Given this list of marker genes Atp11a, Ms4a6d, Rab8b, Aebp2, Ddit4, Car13 (NCBI Gene Id 71934), Srp9, Tarm1, Kmo, Actn1, Nup88, Malt1, AA467197, Ffar2, Lilrb4b, Fcgrt (NCBI Gene Id 14132), Fosl2, Cd209e, Vdr, Gpr132, Fkbp1a, Zfand3, Tle3, St8sia4, Plekhg2 (pleckstrin homology domain containing, family G (with RhoGef domain) member 2), Map3k14, Bzw2, Zfp593, Id2, Acvr2a, Stk39, Rgs1, Syncrip, Clec4n, Ccdc102a, Pfkp, Apobec3, St6gal1, Apod, Serpina3g, Spred1, Rab14, Cd40, Tnfrsf11a, Prnp, Il1rn, Pcgf5, Mt1, Dynlrb1, Hbegf, Rtn4, Riok3, Ccnd2, Cd164, Hax1, Myh9, Samsn1, Cyp7b1, Cfl1, Klf9, Batf3, Cdk6 (NCBI Gene Id 330039), Ass1, Edem1, Vasp, Idi1, Arfgap3, Foxn3, Pogk, Arpc2, Map1lc3b, Litaf, Scn3a, Il4i1, Plet1, Arl8b, Ptger4, Slc30a4, Ngfr, Vcp, Rbx1, Eif5a, Dad1, Relb, Adam23, Zfp106, Marcks, Gpat4, Vmp1, Casp8, Rab7, Ikzf4, Pdcd1lg2, Eif3c, Hsbp1, Il1b, Wnk1, Swap70 (SWA-70 protein), Nipal1, Med15, Plekha1, Socs2, Stxbp6, Snd1, Abracl, Fdx1, Stat3, Cyria, Cyth1, Trpv2, Ddx6, Ms4a4c, Mrc1, Kdm6b, Rpain, Wfdc17, Atp1a1, Ext1, Csrp1, Hnrnpa3, Orai1, Eif2s1, Nckap1l, Itgb1, Btg1, Rabgap1l, Ubxn2a, Ncl, Tmed5, Necap2, Noct, Psme2, Gpr171, Ywhaq, Ly6a, Mrpl20, Pim1, Sec11a, Ccl12, Cox17, Cd300lf, Galnt7, Mbd2, St7, Tnip2, Col27a1, Abtb2, Psma6, Jtb, Casp6, Arhgap31, Arl5a, Ier3, Sf3b6, Eif6, Fh1, Rnf7, Socs3, Nfkb1, Tspan13, Aamp, Cish, Eif1ax, Zfp36l1, Sh3bgrl, Bcl3, Cd86, Xxylt1, Fndc10 (NCBI Gene Id 230991), Nfkbia, Nr4a3, Cd274, Uqcrfs1, Tmem123, Bzw1, Itm2c, Mob3a, Jaml, Ramp3, Gadd45b, Chd7, Sinhcaf, Slc7a11, Pde1b, Ehd1, Psmb7, Nfkb2, Gnai3, Etv3, Tubb6, Ly75, Cct3, Sh3pxd2b, Ptpn2, Lgmn, Clic4, Manf, Cflar, Runx3, Cdkn1a, Hs3st3b1, Pdlim5, Tfec, Cxcl16, Tagln2, Mllt6, Gmppb, Irf5, Socs1, Tpm3, Lrrk1, Cyrib, Uck2, Slc7a5, Ak2, Stat4, Slc33a1, Rcl1, Dusp2, Erh, Cfp, Kdm5c, Stat5a, Ahcyl2 (NCBI Gene Id 74340), Ube2i, Bcl2a1d, Gfra2, Pacsin2, Wtap, Dusp5, P2ry10, Ccr1 (C-C motif chemokine receptor 1), Ifitm2, Diaph1, Csrnp1, Crem, Id1, Sphk1, Ctsz, Ggta1, Cdk2ap2, Lrrc59, Zfc3h1, Syngr2, Prdm1, Mon1b, Il4ra, Csf2rb, Birc3, Mfhas1, Emd, Myo1g, Pik3r1, Adam8, Snap23, Ccl17, Mthfs, Arhgap30, Anxa2, Eif4a1, Fyn, Sdhaf1, Fkbp5, Ube2f, Gcnt2, Arap2, Rabep1, Plscr1, Rap2a, Fchsd2, Pnp (NCBI Gene Id 18950), Fabp5, Hif1a, Scimp, Slfn2, Nudt17, Mif4gd, Tpm4, Gpr183, Myl6, Srf, Mkrn1, Bcl2a1b, Actg1, Plk2, Zdhhc6, Dok2, Rras2 (related RAS viral (r-ras) oncogene 2), Rexo2, Pmvk, Nectin2, Nras, Ost4, Cd63, Nuak2, Lmnb1, Ube2j2, Tmbim1, Adprh, Ifitm1, S100a6, Basp1, Oasl2, Myl12a, Eloc, Timd4, Eif1, Hsd11b2, Mdh2, Hnrnpll, Lrrc8c, Nfil3, Trip12, Pfn1, Ppa1, Zfp296, Lilrb4a, Ube2m, Psmd11, Fem1c, Mir155hg, Picalm, Ccr7, BC031181, Calr, Rab21, H2-Eb2, Pkib, Gsr, Fabp4, Flot1, Ptpn4, Mt2, Rspry1, Sar1a, Map4k4 (mitogen-activated protein kinase kinase kinase kinase 4), Ankrd33b, Srsf2, Dab2, Tmem131l (NCBI Gene Id 229473), Fth1, Arfgap2, Bach1, Marcksl1, Cytip, Rel, Pgk1, Rbm3, Prkcd, Txndc17, Ciao2b, Rai14, Sdc4, Fscn1, Htr7, Arpc5, Frmd4b, Ccl22, Dnajb9, Enah, Adora2a, Psma3 (NCBI Gene Id 19167), Snn, Snx3, Siglece, Anxa3 (NCBI Gene Id 11745), S100a4, Rassf2, Prpf31, Hnrnpk, Serpinb9, Csf2rb2, Tbc1d4, Kif1a, Eif4e2, Lad1, Sertad2, Lfng, Cd80, Pgs1, Tes, Tmem131, Dnajb6, Jak2, Traf1, Mvp, Eva1b, Birc2, Adpgk, Etf1, Il7r, Prps1 (NCBI Gene Id 97786), Pnpla8, Tspan3, Cd83, Etv6, Il6, Vim, Glipr2, Cd53, Hemk1, Nfat5, Cst3, Smarce1, Fcgr2b, Tmem65, Tbc1d1 (NCBI Gene Id 79105), Creb5, Sod2, Cacnb3, Gpbp1, Bhlhe40, Gramd4, Gnb4, Pik3r5, Wdr1, Rftn1, Srgn, Gimap1, Ptpn1, Nrp2, Iscu, Tbc1d15, Morf4l2, Sav1, Xbp1, Cdh1, Bcl2a1a, Gpr35, Pla2g15, Gnb1, Dennd5a, Txnrd1, Rap2b, Bmp2k, Ch25h, Arid5a, Kcnk6, Psmb6, Slamf1, Spint1, Pdcl3, Havcr2, Fnbp1l, Rab10, Pdia6, Icam1, Prr13, Adcy6, here is a description of the gene set: Cytokines mediate cell-cell communication in the immune system and represent important therapeutic targets. A myriad of studies have highlighted their central role in immune function, yet we lack a global view of the cellular responses of each immune cell type to each cytokine. To address this gap, the authors created the Immune Dictionary, a compendium of single-cell transcriptomic profiles of more than 17 immune cell types in response to each of 86 cytokines (>1,400 cytokine-cell type combinations) in mouse lymph nodes in vivo. A cytokine-centric view of the dictionary revealed that most cytokines induce highly cell-type-specific responses. For example, the inflammatory cytokine interleukin-1β induces distinct gene programmes in almost every cell type. A cell-type-centric view of the dictionary identified more than 66 cytokine-driven cellular polarization states across immune cell types, including previously uncharacterized states such as an interleukin-18-induced polyfunctional natural killer cell state. studied in species Mus musculus Genes positively differentially expressed in cell type: cDC2 (conventional dendritic cell type 2) upon treatment with cytokine: IL-1β in mouse lymph nodes in vivo. from publication Cui A, Huang T, Li S, Ma A, Pérez JL, Sander C, Keskin DB, Wu CJ, Fraenkel E, Hacohen N (PMID 38057668) Mouse Gene Set: CUI_CDC2_IL1B_RESPONSE_UP